Given this list of marker genes EHD1, PAICS, LSS (lanosterol synthase), FRAT1, DDX56, CCDC191, RCL1, OXCT1, GTF2IRD1, COL23A1, GNG7, HCN3, CTPS1, WNT10B, IL21R, OAT, PFKFB4, ASAH2, SMPD2, ETNK1, ZNF354C, KBTBD11, ST8SIA6, CA12, FCGRT, SATB1, PARD3, SUPT3H, TSPYL4, TSC22D3, LAS1L, MDN1 (midasin AAA ATPase 1), RPL13, TARBP2, RSAD2, RNF220, CNR2, KRI1, RGCC, FOXRED1, RFX4, WNT9B, SLC39A8, COQ8A, PECR, PLCG1, METTL3, LYRM9, PRRG1, GK5, BBOF1, INSIG1, IL27RA, MAX, RBM18 (NCBI Gene Id 92400), ENOPH1, STAMBPL1, TRMT1, UTP15, FOCAD, SLC29A2, ARMC6, MORC2, ASH2L, SRPX2, PAK6, FDFT1, ABHD11, GNL3, DDRGK1, NDUFA9, PPP1R35, TARS2, TAF5L, SLC35G1, ICOS, TRPC4AP, FAM118A, MATK, ICE2, TSPAN9, ENAM, GPR15, SLPI, PDE4B, HIVEP3, PANK4, METTL13, RNMT, SVIL, SNAP29, ART3, DOK4, DNAAF1, DENND11, EPSTI1, CEP97, TCAF2, TFAP2E (NCBI Gene Id 339488), RAB3IP, EID2, HDAC3, MTA3, TRUB1, PHYHD1, FAM234B, IZUMO1, UNC5CL (NCBI Gene Id 222643), AMZ2, EPB41, AKAP1, SMAD7, ARMC7, BBS9, THEM6, TP53, PHYHIP, PTOV1, TRIM67, DISP2, ADGRG3, YRDC, PFN2, XRCC5, IRGM (NCBI Gene Id 345611), HDAC4, GNL1, ZNRF1, LPCAT1, HABP4, TBCEL, SYT6, CLMN, SQLE, TSACC (NCBI Gene Id 128229), NINJ2, PPP2R5A, CXCR6, FLVCR1, CDH1, TRIM44, FASTKD2, MAP4K2, PCGF6, MX2, COX18, FAM86B2, MAP3K14, RABGGTB, CCNA1, CNGA1, DHODH, C1orf131, RASIP1, ZNF408, LRRC3, AQP9, ZNF777, NOP2 (NOP2 nucleolar protein), GUCA1A, PRPS2, AK7, PDE8B, MAMDC4 (MAM domain containing 4), ARHGDIG, GPR88, KCTD13 (potassium channel tetramerization domain containing 13), TNIP2, CBR1, PRG4, CDC14B, LZTFL1, MUSK, XXYLT1, BGN, TRAP1, ZFAND1, EMG1 (NCBI Gene Id 619532), CTNNBL1, RPS27, PPIL6, RNF138, EIF2B2, CDR2, TRAF3IP3, STOML1, RALYL, RDH12, CD69, MRLN, IDUA, ADI1, ADAMTSL5, METAP1D, PPM1H, QTRT1, TCL1A, KIF2B, DMRTA1 (DMRT like family A1), SOX12, here is a description of the gene set: Genes up-regulated in marginal zone B cells versus day 7 plasma cells. To obtain insight into the genetic basis of the increase of functional activity of memory B cells over time, we compared the gene expression profiles of day 7 and day 40 NP-specific/IgG1 memory B cells, GC B cells and plasma cells in immunized WT mice and naïve B cells, before and after activation in vitro. Human Gene Set: GSE11961_MARGINAL_ZONE_BCELL_VS_PLASMA_CELL_DAY7_UP studied in species Homo sapiens from publication Kaji T, Ishige A, Hikida M, Taka J, Hijikata A, Kubo M, Nagashima T, Takahashi Y, Kurosaki T, Okada M, Ohara O, Rajewsky K, Takemori T (PMID 23027924)